The following is a description of a gene set: Human Gene Set: GOBP_STRESS_INDUCED_PREMATURE_SENESCENCE A cellular senescence process associated with the dismantling of a cell as a response to environmental factors such as hydrogen peroxide or X-rays. studied in species Homo sapiens, and this is the list of marker genes: SIRT1, PLA2R1, CDKN1A, WNT16, TP53, MAPK14, BMAL1, MAPKAPK5